Given this list of marker genes SNX15, PRTN3, PAFAH2, ATF4, ST3GAL2, BTG2, NDC1, PNCK, COX8A, DHRS4, HNMT, PHLDA1, FSTL1, JPT1, EXOC4, ZNF821 (NCBI Gene Id 55565), AFAP1L1, CEP72, APOO, ESCO2, TADA3, CELA1, SLC1A5 (solute carrier family 1 member 5), IRAK1BP1, ARMCX6, KIF23, NICN1, DFFA, CRLF2, KIF18B, PLSCR1, FAM114A2, HACD4, SDR39U1, HIGD2A (NCBI Gene Id 90241), ORMDL3, REEP4, SNX7, RHOBTB3 (Rho related BTB domain containing 3), GADD45A, RSPH3, CBY1, TBC1D31, FMC1, PAQR5, SOCS3, SDHC, ACSS2, RPIA, JOSD2, BAZ1B, PIK3CG, YRDC, DDX39B, TRPC4AP, H1-0, ZFPL1, ARHGAP12, VIM, IL11RA, WBP1L, NABP2, ACTN4, HLF (NCBI Gene Id 3131), FARS2, CCNA2, PHF12, RNF167, FXYD1, TWSG1, ICA1 (islet cell autoantigen 1), IER3IP1, APP, TJP3 (NCBI Gene Id 27134), DEPDC1B, TTC38, PIMREG, DEPDC1, IQGAP3, TRIM3, CRIM1, GBP2, SNRNP27, ING2, DENND1A, IFT81, LYPD6B, MRPL33, EME1, GORASP1, TRAPPC3, G6PC3, IL1R1, REX1BD, AKAP8L, ZCCHC17, MRPL34, LAIR1, DAPK3, ANAPC10, ALDOC, CEBPA, RNF220, TNFAIP3, PRRC2A, GPRASP2, NAT9, ZC3H7B (zinc finger CCCH-type containing 7B), GSTM5, EPB41L3 (erythrocyte membrane protein band 4.1 like 3), RAP2A, GAS8, PPFIBP2, SERPINF1, KIZ, MPO, SPNS2, ITGA6, KLF12, ASCC1, RACGAP1, TMEM43, BBS4, SUGT1, KIF2C, FAHD1, SAV1, ESAM, ISG20, MED8, OTUD3, FBXO17, OXGR1, GPSM2, TSSC4, ARHGAP6, MUC13, OAF, PRKG1, C12orf71, CENPV, CD274, FADS2, SMIM11, FGL2, MAP2K3, KYAT1, RNF5, KNSTRN, TRADD, GCLM, PIGM, ATP5F1D, BUB1B, TRIP10, TIMM10B, DCAF4, MC5R (melanocortin 5 receptor), TCEAL1, SH3GL1, TACSTD2, CTSG, DNAH12, ADAMTS1, FBXL14 (NCBI Gene Id 144699), MASTL, CCSER1, CHCHD5, APBA3, SKA1, VLDLR, CCL4, CORO1B, CDCA2, CRELD1, PGK2 (NCBI Gene Id 5232), CXCL3, TPX2, PGLYRP1, MIS18BP1, ITFG2, RBX1, SGO2, MICALL2, GPC5, H3C4, NEIL3, RNF144B, CDADC1, DUSP2, RAD54B, NEAT1, ITIH5, ACSF3, CKS2, USB1, TUBB2A, RGS3, here is a description of the gene set: from publication Kim TD, Terwey TH, Zakrzewski JL, Suh D, Kochman AA, Chen ME, King CG, Borsotti C, Grubin J, Smith OM, Heller G, Liu C, Murphy GF, Alpdogan O, van den Brink MR (PMID 18178870) Transcriptional response of murine allogeneic T cells (B10.BR) after stimulation with different organ-derived (spleen, liver, peripheral and mesenteric lymph nodes) dendritic cells (C57BL/6) in vitro species: Homo sapiens Human Gene Set: GSE5503_MLN_DC_VS_PLN_DC_ACTIVATED_ALLOGENIC_TCELL_UP Genes up-regulated in allogeneic T cells after stimulation with dendritic cells from lymph nodes: mesenteric (mLN) versus peripheral (pLN).